Given this list of marker genes BAD, GNAI1, PIK3CA, CXCR4, PIK3CD, GNAI3, AKT1, CCR5, AKT2, AKT3, GNAI2, PIK3CB, here is a description of the gene set: Human Gene Set: KEGG_MEDICUS_PATHOGEN_HIV_GP120_TO_CXCR4_GNAI_PI3K_BAD_SIGNALING_PATHWAY HIV gp120 to CXCR4-GNAI-PI3K-BAD signaling pathway. Pathway ID: N00431. Pathway type: Pathogen. Pathway class: nt06161 Human immunodeficiency virus 1 (HIV-1). Pathway Definition from KEGG: Env -> (CXCR4,CCR5) -> GNAI -> PI3K -> PIP3 -> AKT -| BAD species: Homo sapiens